The following is a description of a gene set: The series of molecular signals initiated by binding of a ligand to the tyrosine kinase receptor ERBB3 on the surface of a cell, and ending with the regulation of a downstream cellular process, e.g. transcription. ERBB3 receptors have impaired kinase activity and rely on the kinase activity of the heterodimer partner for activation and signal transmission. Mouse Gene Set: GOBP_ERBB3_SIGNALING_PATHWAY studied in species Mus musculus, and this is the list of marker genes: Rtn4, Grb2, Raf1, Mapk1 (NCBI Gene Id 98012), Nrg1, Erbb2, Map2k2, Myoc, Nrg2, Sos1, Erbb3, Map2k1, Hras, Mapk3